The following is a description of a gene set: Human Gene Set: GOBP_ETHER_BIOSYNTHETIC_PROCESS species: Homo sapiens The chemical reactions and pathways resulting in the formation of ether., and this is the list of marker genes: FASN, DHRS7B, PEDS1, GNPAT, PLA2G4A, LPCAT2, PLA2G4C, AGPS, FAR1, CHPT1, SELENOI, PEX7, ALOX5